Given this list of marker genes GUK1, AK2, AK1, AK4, AK6, CMPK1, GLRX, NUDT13, here is a description of the gene set: The chemical reactions and pathways by which a nucleobase, nucleoside or nucleotide small molecule is synthesized from another nucleobase, nucleoside or nucleotide small molecule. Human Gene Set: GOBP_NUCLEOBASE_CONTAINING_SMALL_MOLECULE_INTERCONVERSION studied in species Homo sapiens